Given this list of marker genes TRIOBP, TWF1 (NCBI Gene Id 82712), ESPNL, OTOG, LHFPL5, USH1G, TWF2, MYH9, CHRNA10, SLC26A5, USH1C, EPB41L1, EPS8, KCNMA1, RDX, WHRN, RIPOR2, FSCN2, MPP1, KCNQ4, SPTBN1, CDH23, OTOGL, ESPN, TMIE, TMC1, GSN, TMC2, CASK, ACTG1, EPS8L2, MYO3B, STRC, CIB2, XIRP2, ATP2B2, PLS1, ACTB, EPB41L3, TPRN, MYO7A, MSN, MYO3A, GRXCR2, EZR, PCDH15, PJVK, GRXCR1, KCNN2, MYO1C, MYO15A (NCBI Gene Id 51168), CLIC5, CHRNA9, KCNMB1, SPTAN1, here is a description of the gene set: Outer hair cells (OHCs) produce amplification of sound waves in the cochlea by shortening and lengthening in response to sound, a phenomenon called electromotility. Like inner hair cells, OHCs possess apical stereocilia arranged in rows of ascending height. A taller stereocilium is connected to a shorter stereocilium by a tip link comprising a CDH23 dimer onthe side of the taller stereocilium and a PCDH15 dimer on theapex of the shorter stereocilium. PCDH15 interacts with LHFPL5, a subunit of the mechanoelectrical transduction channel complex (MET channel, also called the mechanotransduction channel), which contains TMC1 or TMC2, TMIE, CIB2, and LHFPL5. Deflection of the stereocilia in one direction produces tension on the tip link that increases the open probability of the MET channel, resulting in depolarization of the OHC. Deflection of the stereocilia in the opposite direction produces compression on the tip link that decreases the the open probability of the MET channel, resulting in hyperpolarization of the OHC.<br>Sound causes micromechanical motions of the organ of Corti that result in alternating tension and compression in the tip link that produce excitatory-inhibitory cycles of MET channel openings and closings relative to the MET channel's resting open probability. This causes directionally alternating fluxes of K+ and Ca2+, yielding depolarization-hyperpolarization cycles that cause conformational changes in prestin (SLC26A5). These cycles are asymmetrical, with contraction caused by depolarization dominating elongation caused by hyperpolarization due to the asymmetry of the open probability of MET channels. Stereociliary ATP2B2 (PMCA2) extrudes calcium ions and basally located KCNQ4 extrudes potassium ions to repolarize the OHC. <br>Depolarization of the OHC causes a decrease in length of the OHC due to a very rapid, voltage-sensitive change in conformation of the membrane protein prestin (SLC26A5), an unusual member of the anion transporter family located in the lateral membrane that appears to respond to cytosolic chloride by altering its conformation in the plane of the plasma membrane. Prestin also appears to act as a weak chloride-bicarbonate antiporter. Changes in length of the OHCs cause movement of the reticular lamina toward and away from the basilar membrane. Reactome Pathway: Sensory processing of sound by outer hair cells of the cochlea species: Homo sapiens part of: Sensory processing of sound